The following is a description of a gene set: One of the hallmarks of the Planar Cell Polarity pathway is the asymmetric distribution of proteins on opposite membranes of a single cell. In Drosophila, Stbm and Pk (homologues to the human VANGL1/2 and PRICKLE1/2/3) colocalize opposite Fz, Dsh and Dgo (FZD, DVL, and ANKRD6, respectively). The two complexes antagonize each other, with Fz:Dsh:Dgo acting to promote signaling downstream of Dsh, while the Stbm:Pk complex restricts this signaling. Asymmetric localization of some PCP proteins is also seen in vertebrates although the patterns of localization differ from that of flies. The details of how localization is established and how the asymmetrical distribution of proteins is translated into gross morphological processes remain to be fully elucidated. studied in species Homo sapiens Reactome Pathway: Asymmetric localization of PCP proteins part of: PCP/CE pathway, and this is the list of marker genes: PSMB1, PSMC1, UBB, PSMD8, PSMD1, PSMC2, PSMD6, DVL2, PSMD14, PSMB4, PSMB3, PSMB2, VANGL2, PSMD13, PRICKLE1, PSMA4, FZD8, WNT5A, PSMA3, PSMA2, PSMA7, PSMD12, PSMA6, FZD3, FZD5, UBC, PSMA5, PSMD3, PSMB6, FZD7, PSMD7, PSMC5, UBA52, PSMB7, FZD4, PSMA1 (NCBI Gene Id 5682), PSMB5, ADRM1, PSMD2, FZD2, SMURF1, PSMC4, FZD1, PSMC3 (proteasome 26S subunit, ATPase 3), PARD6A, PSMC6, SMURF2, PSMD11 (NCBI Gene Id 5717), SEM1, RPS27A, SCRIB